Given this list of marker genes PNLIP, PNPLA2, LIPE, CEL, PNPLA4, PLB1, RPE65, here is a description of the gene set: Human Gene Set: GOMF_RETINYL_PALMITATE_ESTERASE_ACTIVITY studied in species Homo sapiens Catalysis of the reaction: retinyl palmitate + H2O = retinol + palmitate + H+.